The following is a description of a gene set: Any process that activates or increases the frequency, rate or extent of T-helper cell differentiation. Mouse Gene Set: GOBP_POSITIVE_REGULATION_OF_T_HELPER_CELL_DIFFERENTIATION studied in species Mus musculus, and this is the list of marker genes: Ccr7, Malt1, Il18, Il4ra, Nlrp3 (NCBI Gene Id 216799), Ripk2, Nfkbiz, Rara, Mir326, Brd4, Hlx, Nfkbid, Irf1, Ccr2, Shb, Il6, Ccl19, Anxa1, Tnfsf4, Brd2, Socs5, Il23a, Prkcz, Ep300, Opa1